The following is a description of a gene set: studied in species Homo sapiens Human Gene Set: GOMF_COLLAGEN_BINDING_INVOLVED_IN_CELL_MATRIX_ADHESION Any collagen binding that occurs as part of cell-matrix adhesion., and this is the list of marker genes: ITGB1, ITGA10, ITGA1, ITGA2, ITGA11